The following is a description of a gene set: Human Gene Set: GOBP_T_HELPER_1_TYPE_IMMUNE_RESPONSE species: Homo sapiens An immune response which is associated with resistance to intracellular bacteria, fungi, and protozoa, and pathological conditions such as arthritis, and which is typically orchestrated by the production of particular cytokines by T-helper 1 cells, most notably interferon-gamma, IL-2, and lymphotoxin., and this is the list of marker genes: SLAMF1, IL27RA, SLC11A1, CD80, IL1B, LGALS9, SPN, NLRP10, STAT4, TBX21, HLA-DRB1, TMEM98, IL33, PLA2G4A, BCL3, HMGB1, TRAF6, IL27, EBI3, IL4R, HAVCR2, HLX, MTOR, ANXA1, IL1RL1, RELB, STAT6, LEF1, IL23R, XCL1, TNFSF4, IL18 (NCBI Gene Id 3606), NFKBIZ, ASCL2 (NCBI Gene Id 430), SEMA4A, IL1R1, CCL19, HRAS, RIPK2, ARID5A, IL18R1, CCR2, IL23A, IL12B, IL12RB1, CRACR2A, SOCS5, TLR4, JAK3, IL18BP